Given this list of marker genes MIR103A1, EDN1, GH1, C1QTNF12, IGF1, TNF, CLIP3, PEA15, CTNND1 (NCBI Gene Id 82168), GRB10, ENPP1, IL1B, FGF21, ARPP19, NFE2L2, OSBPL8, CERS1, SLC1A2, ITLN1, PRKAG2, RAP1A, FABP5, MIR143, PRKCB, INPP5K, POU4F2, CAPN10 (calpain 10), IRS2, OCLN, HK2, RSC1A1, SELENOS, AKT1, ERFE, TRIB3, RTN2, PRKCI, CREBL2, EDNRA, FFAR4, RNASEL, SIRT6, C3, PID1, STXBP3, BRAF, PTPRM (protein tyrosine phosphatase receptor type M), PIK3R1 (phosphoinositide-3-kinase regulatory subunit 1), AKT2, APPL2, PTH, FGF19, NR4A3, KLF15, YES1 (YES proto-oncogene 1, Src family tyrosine kinase), MEF2A, INSR, ASPSCR1, SORBS1, INS, MAPK14, C2CD5, MIR107, ZDHHC7 (zinc finger DHHC-type palmitoyltransferase 7), TERT, GSK3A, PLA2G1B, GPC3, OSTN, RHOQ, IRS1, APPL1, PTPN11, ADIPOQ, LEP, CLTCL1, MIR223, OPN3, STXBP4, SLC25A27, here is a description of the gene set: studied in species Homo sapiens Any process that modulates the frequency, rate or extent of glucose transport across a membrane. Glucose transport is the directed movement of the hexose monosaccharide glucose into, out of or within a cell, or between cells, by means of some agent such as a transporter or pore. Human Gene Set: GOBP_REGULATION_OF_D_GLUCOSE_TRANSMEMBRANE_TRANSPORT